Given this list of marker genes Bmyc, Slco1b2, Cyp2a5, Pde4b, Prnp, Acer2, Gstm1, Rora, Cyp3a41a, Cyp2c29, Fbp1, Aox4, Ccl4, Cad, Gsto2 (NCBI Gene Id 78155), Sult2a3, Kcnc1, Itgb3, Gpld1, Asic2, Pon3, Lpo, Cryz, Sult2a4, Fmo5, Cyp2b9, Ugt2b1, Gstm5, Cyp2c23, Gsta3 (glutathione S-transferase, alpha 3), Cyp2c54, Pcna, Myc, Cyp1a1, Gstm6, Ppm1f, Ppp1r12a, Aox1, Fmo3, Gsto1, Wnk4, Nkx3-1, Il1b, Slco1a1, Prkaa1, Ahrr, Mef2c, Sult2a6, Cyp2b10, Uchl1, Cyp2d11, Slco1a6, Cers1, Fmo1, Gstm3, Mir7116, Cyp2j13, Cyp2b13, Cyp2j11, Chek2 (checkpoint kinase 2), Gstp-ps, Slamf8, Sult1b1, Star, Gsta1, Cyp2c38, Kcnh2, Abca1, Sult2a7, Aldh2, Gas6 (growth arrest specific 6), Cyp2c65 (cytochrome P450, family 2, subfamily c, polypeptide 65), Mylk, Cyp2c70, Gsta2 (NCBI Gene Id 14858), Uchl1os, Cyp2w1 (cytochrome P450, family 2, subfamily w, polypeptide 1), Cyp2g1, Cyp2f2, Fmo4, Th, Akr1c12, Akap5, Tfrc (transferrin receptor), Slc10a1, Cyp1b1, Gstp1, Gsta13, Nr1i2, Cyp2s1, Cyp2c67, Grin1, Kcnq1, Cyp2j8, Cyp26a1, Fancb, Cyp3a11, Cyp2c55, Adipoq, Acsl1, Blm, Tpmt, Acaa1a, Cyp2a4, Pax6, Cyp2a22, E2f1, Nos1, Gsta5, N6amt1, Acaa1b, Mcm7, Cyp2d22, Cyp2c68, Pde4a, Rest, Slc18a2, Sufu, Gstm7, Ugt1a6a, Cyp3a16 (cytochrome P450, family 3, subfamily a, polypeptide 16), Cyp2b19, Cyp3a44, Ren1, Cbr1, Cyp2u1, Cyp46a1, Braf, Ugt1a1 (UDP glucuronosyltransferase 1 family, polypeptide A1), Cyp1a2, Vkorc1, Rap1a, Cyp2c66, Cyp2c69, Egfr, Dpep1, Aim2, Abcc1, Prkaa2, Umps, Ugt1a6b, Crhbp, Tlr3, Ankrd1, Gsta4, Nr1h4, Cyp2ab1, Cyp2d10, Hnf4a, Ehmt2, Akr1c13, Cdh13, Cyp2d34, Aox3, Cyp2a12, Gstp2, Cyp26b1, Cyp2j12, Nfe2l2, Aip, Nudt15 (NCBI Gene Id 214254), Cyp2d26, Abcc2, Sult2a1, Fmo2, Ccl2, Aox2, Recql5, Cyp2b23, Gstm4, Cyp2j6, Cyp2j7, Gstt1, Abcc9, Ppp1r9b, Nceh1, Edn1, Cyp2j9, Sult2a2, Crkl, Cd69, Cyp2r1, Cyp2c37, Kcnq2, Cyp2c40 (cytochrome P450, family 2, subfamily c, polypeptide 40), Sult1c1, Cyp2c39, Cyp2d9, Rap2a, Serpine1, Sult2a5, Nos2, Cyp2e1, Abcb11, Rbm22, Ppp1r14a, Rorc, Kcnq3, Rap1b, Ahr, As3mt, Gstp3, Trp53, Sult2a8, Kcne2, Cyp3a41b, Ppm1e, Mcpt1, Cbr1b, Cyp2d12, Cyp2c50, Adm, Guk1, Cyp2t4, Htr1b, Cyp2j5 (NCBI Gene Id 13109), Sox10, Rb1, Sult1a1, Rnf149, Gstm2, here is a description of the gene set: Any process that results in a change in state or activity of a cell (in terms of movement, secretion, enzyme production, gene expression, etc.) as a result of a stimulus from a xenobiotic, a compound foreign to the organism exposed to it. It may be synthesized by another organism (like ampicilin) or it can be a synthetic chemical. Mouse Gene Set: GOBP_CELLULAR_RESPONSE_TO_XENOBIOTIC_STIMULUS species: Mus musculus